The following is a description of a gene set: The series of events in which a mechanical stimulus is received and converted into a molecular signal as part of sensory perception. Human Gene Set: GOBP_DETECTION_OF_MECHANICAL_STIMULUS_INVOLVED_IN_SENSORY_PERCEPTION studied in species Homo sapiens, and this is the list of marker genes: TMC1, ASIC3, PHF24, CXCL12, WHRN, ASIC2, REST, MKKS, PIEZO2, SCN1A, KCNQ1, CHRNA10, BACE1, ADGRV1, COL11A1, FYN, TRPA1, KIT, KCNA1, SCN9A, PDZD7, SCN11A, TMC2, PJVK (pejvakin), NTRK1, TMEM120A, STRC, PTPRQ, ITGA2, KCNK2, LHFPL5, HTR2A, TNF, TMEM87A, CHRNA9, HPN, KCNK4, MYC, SERPINE2